Given this list of marker genes MCM3, CYP27A1, SH2D3C, KCNH2 (potassium voltage-gated channel subfamily H member 2), BCAP31, CCR2, STYXL1, ARRB1, DYNLL1, PDZK1, HSPA1B, ATP6V1C1, GLB1, NUDT2, CCN5, SLC31A2, ASGR1, METTL13, CD1C (CD1c molecule), HMGCL, EMG1, KIF3C, RAB8A, CORO1A, UROD, PPP1R11, SPIB (NCBI Gene Id 6689), ECHS1 (enoyl-CoA hydratase, short chain 1), HSD17B4, ZNF226, TNFSF13, DAXX, HSPA8, TICAM2, CX3CR1, OAS1, KAT5, RGS3, COMT (catechol-O-methyltransferase), CEBPA (NCBI Gene Id 1050), RPA2, TLR8, MAPK11, FARSA, NFS1 (NFS1 cysteine desulfurase), KIAA0930, TNFSF10, SPOP, FGR (NCBI Gene Id 2268), TRIM21, BTN3A2, LMAN2 (lectin, mannose binding 2), HEXA, PDGFA, LASP1, PSEN1, HYAL2 (hyaluronidase 2), ASH2L, PTRH1, PAAF1, RAB32 (NCBI Gene Id 10981), ZNF154, GOSR2, PTDSS1, ADORA2A, VIPAS39, DTX2, PIM1, VPS45, KCNE3, RTCB, NANS, PHB1, NUBP1, CISD3, EIF2B2, NBR1, RGS14, TLN1, TM9SF1, TCL1A, VPS72, MYBPH, PTPN6, APOL3, PIM3, ICAM2, LPXN, CSF1R, ATP6V1B2, LARP4, BTN3A3, SASH3, VGLL4, CACNA2D3, VAMP8, PUF60 (poly(U) binding splicing factor 60), SRSF5, ENTR1, VCL, ZNF692, CTSZ, FBP1, CSNK2A1, BCAT2, PRPF6, VPS35, DOK2, NUP62, SUPT16H, ING4, CD300LF, EDC4, CISH, SRCAP, FGL2, SEPHS1, TLR5, CD79B, C3AR1, KEAP1, GTF2H4, RBM4, PRMT5, FES, SLC25A20, LAT, MCRS1, OPRL1, CCT3, FKBP15 (FKBP prolyl isomerase family member 15), ATP6V1E1, DDX23, CLU, GBA1, TWF2, CTTN, LAIR1, CCDC22, NIPSNAP1, CD8B, UTP14A, SNRNP40, here is a description of the gene set: studied in species Homo sapiens Gene expression in human peripheral blood mononuclear cells was systematically evaluated following smallpox and yellow fever vaccination, and naturally occurring upper respiratory infection (URI). All three infections were characterized by the induction of many interferon stimulated genes, as well as enhanced expression of genes involved in proteolysis and antigen presentation. Vaccinia infection was also characterized by a distinct expression signature composed of up-regulation of monocyte response genes, with repression of genes expressed by B and T-cells. In contrast, the yellow fever host response was characterized by a suppression of ribosomal and translation factors, distinguishing this infection from vaccinia and URI. No significant URI-specific signature was observed, perhaps reflecting greater heterogeneity in the study population and etiological agents. Taken together, these data suggest that specific host gene expression signatures may be identified that distinguish one or a small number of virus agents. Genes down-regulated in peripheral blood mononuclear cell (50 to 60)d vs 0d in adults (18-32) after exposure to APSV Wetvax, time point 50 to 60D Human Gene Set: SCHERER_PBMC_APSV_WETVAX_AGE_18_32YO_50_TO_60DY_DN from publication Scherer CA, Magness CL, Steiger KV, Poitinger ND, Caputo CM, Miner DG, Winokur PL, Klinzman D, McKee J, Pilar C, Ward PA, Gillham MH, Haulman NJ, Stapleton JT, Iadonato SP (PMID 17651872)